The following is a description of a gene set: Up-regulated cis-regulated expression quantitative loci (cis-eQTL) in the heart that were identified as candidate genes for the regulation of left ventricle mass (LVM). from publication Petretto E, Sarwar R, Grieve I, Lu H, Kumaran MK, Muckett PJ, Mangion J, Schroen B, Benson M, Punjabi PP, Prasad SK, Pennell DJ, Kiesewetter C, Tasheva ES, Corpuz LM, Webb MD, Conrad GW, Kurtz TW, Kren V, Fischer J, Hubner N, Pinto YM, Pravenec M, Aitman TJ, Cook SA (PMID 18443592) Left ventricular mass (LVM) and cardiac gene expression are complex traits regulated by factors both intrinsic and extrinsic to the heart. To dissect the major determinants of LVM, we combined expression quantitative trait locus1 and quantitative trait transcript (QTT) analyses of the cardiac transcriptome in the rat. Using these methods and in vitro functional assays, we identified osteoglycin (Ogn) as a major candidate regulator of rat LVM, with increased Ogn protein expression associated with elevated LVM. We also applied genome-wide QTT analysis to the human heart and observed that, out of 22,000 transcripts, OGN transcript abundance had the highest correlation with LVM. We further confirmed a role for Ogn in the in vivo regulation of LVM in Ogn knockout mice. Taken together, these data implicate Ogn as a key regulator of LVM in rats, mice and humans, and suggest that Ogn modifies the hypertrophic response to extrinsic factors such as hypertension and aortic stenosis. studied in species Rattus norvegicus Human Gene Set: PETRETTO_LEFT_VENTRICLE_MASS_QTL_CIS_UP, and this is the list of marker genes: SLC28A3, TMEM14C, OGN, MCUR1, RNF182, MACROH2A1